Given this list of marker genes Arid5a, Endou (NCBI Gene Id 19011), Ncor1, Trp53, Fez1, Qki, Tent5a, Fbxo43, Cidea, Adra1a, Dedd, Igf2bp2, Wnk1, Secisbp2 (SECIS binding protein 2), Zfp36, Dysf, Nop53, Nmnat1, Rbm10, Ago2, Klhl22, Washc1, Ogt, Hmgcr, Nsun2, Tirap, Nos2, Mtch2, Scfd1, Traf2, Cyp51, Sec22b, Thrap3 (thyroid hormone receptor associated protein 3), Rbm47, Trim40, Sufu, Cptp, Rnf41, Tigar, Dazl, Zc3h14, Gimap3, Usp8, Apoa2, Pdcl3, Hdac6, Lrrk2, Wac (WW domain containing adaptor with coiled-coil), Rpl23, Hcar2, Foxk1, Pabpc1, Dapl1, Rragd, Phf23, Ptk2, Naf1, Grin2c, Dhx9, Becn1, Ppp2ca, Atraid, Rubcn, Slc4a1, Mfsd2a, Paip1, Trem2, Rbm46, Zar1, Apobec1, Pink1, Slc7a5, Ubxn1, Axin2, Rgn, Snca, Nqo1, Rps7, Ins2, Itgb1, Ehmt2, Wnt1, Ubqln4, Il17a, Rnf5, Rybp-ps, Alk, Tbc1d14, Sco1, Psmf1, Srsf1, Il10ra, Myd88 (NCBI Gene Id 17874), Dffa, Noct, Marchf7, Poldip2, Dicer1, Snx3, Elavl1, Fez2, N4bp1, Vip, Sirt2, Tsc1, Trdmt1, Traf5, Fhit, Traf3ip2, Gpld1, Lzts1, Adgrb1, Gata4, Myog, Herc1, Nrbp2, Egfr, Mtmr9, Adra1b, Serpine2, Csnk2b, Usp7, Nampt, Tent5b, Mad2l2, Trim27, Dffb, Rybp, Laptm4b, Mlst8, Vegfa, Ptpn22, Hnrnpab, Bmf, Gpi1, Pfkfb1, Mcl1, Prmt6, Nicol1, Pin1rt1, Styx-ps, Pabpn1l, Ddit4, Dbi, Nrg1, Lrig2, Bag6, Hnrnpc, Larp1, Tmem39a, Apoc1 (NCBI Gene Id 11812, apolipoprotein C-I), Csde1, Ikbke, Tnf, Psen2, Tlk2, Git1, Cnr1, Senp1, Htra2, Rraga, Stat3, Apoc3, Il1b, Sirt6, Parn, Hipk2, Oaz1, Bscl2, Slfn2 (schlafen 2), Ep300, Flcn, Rragb, Usp26, Rela (NCBI Gene Id 19697), Larp4b, Ppara (peroxisome proliferator activated receptor alpha), Zdhhc7, Hdac4, Mapkapk2, Foxk2, Lypla1, Aqp11, Hfe, Syncrip (NCBI Gene Id 78260), Ric1, Hnrnpd, Fus, Timp1, Tent5d, Actn3, Lrpprc, Plin5 (perilipin 5), Snx12, Eif4g2, Slc25a12, Gabarapl2, Klhl40, Grin2a, Hnrnpu, Angel2, Wdr6, Rpl5, Usp25, Mad2l1, Upf3a, Psme3ip1, Etfbkmt, Erfe, Atp2b4, Crtc3, Ier3 (NCBI Gene Id 15937), Lamp3, Timp2, Eif4g1, Fam76b, Ppargc1a, Pik3cg, Taf9, Tsc2, Cbfa2t3, Eif4enif1, Smcr8, Hcar1, Trim39, Ctsa, Mtmr2, Cdk5rap3, Igf2bp3, Usp5, Mapk8, Mycbp2, Ptbp1 (polypyrimidine tract binding protein 1), Usp19 (NCBI Gene Id 71472), Stk38l, Slc11a1, Mtor, Furin, Fmc1 (NCBI Gene Id 66117), Dnd1, Tent4a, Hsp90ab1, Slirp, Agap2, Fmn2, Igf2bp1, Adora1, Cidec, Mir466l, F8a, Alad, Zcchc17, Azin2, Mtm1, Dap, Ophn1, Clec16a, A1cf, Qrich2, Acacb, Park7, Mettl14, Rbm38, Usp30, Irak3, Tent5c, Flna, Usp36, Ubxn2a, Timp3, Elavl4, Usp38, Pde3b (phosphodiesterase 3B, cGMP-inhibited), Usp14, Nupr1, Ddrgk1, Eif3h, Gimap5, Fbp1, Tob1, Rilp, Nrde2, Kdm4a, Mettl1, Lepr, Smad3, Caml, Ccar2, Taf15, Pml, Azin1, Map1a, Tent2, Hmox1, Prkaca, Akt1, Sgta, Hnf4aos, Rbm24, Qsox1, Rasip1, Rgp1, Phf20l1, Dhx34, Pbk, Vps13c, Tent4b, Usp9x, Psen1, Npc1 (NPC intracellular cholesterol transporter 1), Csnk2a2, Ldc1, Meioc, Mt3, Anxa2, Fbxl4, Mgat3, Lep, Tnfaip3 (NCBI Gene Id 21929), Rragc, Smad4, Zkscan3, Fn1, Dab2ip, Smarcc1, Sf3b3, Timp4, Pkp1 (NCBI Gene Id 98390), Mettl16, Adra2a, Cirbp, Cst3, Shh, Tspo, Bcl2, Phb1, Golga2, Fyn, Prkaa1, Dkc1, Ttc36, Rptor, Boll, Vps35, Hnrnpa0, Trim63, Ybx1, Nbas, Ptpn3, Dhx36 (DEAH-box helicase 36), Bag5, Styx, Prkcg, Gdnf, Phax, Nell1, Itga5, Pptc7, Sorl1, Tardbp, Rpl11, Il10, Ppp1r3b, Chuk, Cdkn2a (cyclin dependent kinase inhibitor 2A), E2f1, Il3, Ins1, Sgms1os1, Uchl5, Ybx2, Svip (small VCP/p97-interacting protein), Gipc1, Mdm4, Ikbkb, Pkp3, Fxr1, Pin1 (NCBI Gene Id 67670), Anks1, Tmem132a, Sik2, here is a description of the gene set: Any process that stops, prevents, or reduces the frequency, rate or extent of the chemical reactions and pathways resulting in the breakdown of substances. Mouse Gene Set: GOBP_NEGATIVE_REGULATION_OF_CATABOLIC_PROCESS studied in species Mus musculus